The following is a description of a gene set: from publication Yevshin I, Sharipov R, Kolmykov S, Kondrakhin Y, Kolpakov F (PMID 30445619) Genes containing one or more binding sites for (VRTN) in their promoter regions (TSS -1000,+100 bp) as identified by GTRD version 20.06 ChIP-seq harmonization. Human Gene Set: VRTN_TARGET_GENES studied in species Homo sapiens, and this is the list of marker genes: SLC24A1, DAP-DT, SLC33A1, NPHS1, MT-TF, MTIF2, ENSG00000225656, MT-TE, INTS14 (integrator complex subunit 14), SLC4A1AP, APLP1, MTCO3P12, SUPT7L, MT-TT, MTND5P11, PGAM4P2, ZNF668, RNVU1-27, MT-CYB, ZNF646, MT-ND6, MT-RNR1, MIR4477A